Given this list of marker genes EIF2S2, MMS19, TARS1, PABPN1, CDK11A, GARS1, ARIH2, ESD, GNL2, ACTL6A, HNRNPL, MTREX, CS, SRPK1, PKMYT1, RFC4, SFSWAP, TFDP1, PRKDC, DNAJC11, MLEC, NSD2, IARS1, XPO6, POM121 (POM121 transmembrane nucleoporin), TRIP13 (thyroid hormone receptor interactor 13), NUP188, DNMT1, DDX18 (NCBI Gene Id 8886), SEC63, TNPO3, IFRD2, PRPF8, AFG3L2, HNRNPA2B1, THOP1, ZWINT, SSBP1, NUP62, TCOF1, GOT2, SGTA, CCT4 (NCBI Gene Id 10575), NAE1, SRRM1, XPO7, DDX46, TRRAP (NCBI Gene Id 8295), EPRS1, TREX2, ZNF131, VARS1, RUVBL2, TXLNA, BMS1, CDC7, ARID3A, MZF1, RRM1, BUB1B, CAD, SCARB1, ZPR1, HADH, LANCL1 (LanC like glutathione S-transferase 1), SSRP1, PGM1, USP14, PDXDC2P-NPIPB14P, SSB, DFFA, RFC1, NUDC, THOC2, LRPPRC, CHAF1A, KIF20B, MCM2, PLPBP, LSM2 (NCBI Gene Id 57819), POLR2A, YARS1, MCFD2, TM9SF2, DDX39A, KHSRP, GTF2A2, MARS1, EIF3I, IMMT, CEBPZ, RAD54L, GLMN, PREP, ABCF1, NAGA, RPA2, SAFB, BAZ1B, HDAC2, PWP2, ALG3, VDAC3, IDH3A, PABPC4, here is a description of the gene set: Human Gene Set: MORF_RAD54L Neighborhood of RAD54L species: Homo sapiens Neighborhood of RAD54L RAD54-like (S. cerevisiae) in the MORF expression compendium